The following is a description of a gene set: species: Homo sapiens Genes having at least one occurence of the motif AGCGCTT in their 3' untranslated region. The motif represents putative target (that is, seed match) of human mature miRNAs hsa-miR-518f, hsa-miR-518e and hsa-miR-518a (v7.1 miRBase). Human Gene Set: AGCGCTT_MIR518F_MIR518E_MIR518A, and this is the list of marker genes: EGR3, CAPN3, NSG2 (neuronal vesicle trafficking associated 2), FCHSD1, OTP, NRXN1, ZNF608, PTPRU, SON, AUTS2, CPEB1, ZNF385A, BET1L, MCF2L, NEXMIF, TAS1R1, ADO, RAP1B